The following is a description of a gene set: The series of molecular signals in which an intracellular signal is conveyed to trigger the apoptotic death of a cell. The pathway is induced in response to changes in intracellular ion homeostasis, and ends when the execution phase of apoptosis is triggered. Mouse Gene Set: GOBP_INTRINSIC_APOPTOTIC_SIGNALING_PATHWAY_IN_RESPONSE_TO_OSMOTIC_STRESS studied in species Mus musculus, and this is the list of marker genes: Ptgs2, Epo, Scn2a (sodium channel, voltage-gated, type II, alpha), Casp3, Usp15, Bad, Tifab, Ybx3, Bdkrb2